The following is a description of a gene set: studied in species Mus musculus Mouse Gene Set: chr15D2, and this is the list of marker genes: Sla, Gm31342, Dnaaf11, Gm10240, Gm2895, Tmem71, Mir30b, Ccn4, Gm7859, Gm20732, St3gal1, Ndrg1, Tg, 1700012I11Rik, Phf20l1, Zfat, Mir30d